The following is a description of a gene set: Human Gene Set: HP_DYSGRAPHIA Dysgraphia A writing disability in the absence of motor or sensory deficits of the upper extremities, resulting in an impairment in the ability to write regardless of the ability to read and not due to intellectual impairment. species: Homo sapiens, and this is the list of marker genes: EPCAM, CHMP2B, PMS1, APP, MSH6, CLIP2, FGF14, PMS2, SOX6, CHEK2, TMEM240, MSH2, DNAJC30 (DnaJ heat shock protein family (Hsp40) member C30), BMPR1A, BRCA2, PSEN1, MUTYH, POLD1, TMEM106B, TBL2, TREM2, RPS20, VPS37D, MAPT (NCBI Gene Id 8152), ATM, ELN, SPG21, TOMM40, SQSTM1, TMEM270, RFC2, FKBP6, GTF2IRD1, GTF2I, GRN, STX1A, KRAS (KRAS proto-oncogene, GTPase), METTL27, TGFBR2, SORL1, BAZ1B, ABCA7, BUD23, PIK3CA, MLH1, POLE, GTF2IRD2 (NCBI Gene Id 84163), NCF1, VCP, PSEN2, EIF4H, LIMK1, SEMA4A